Given this list of marker genes Upb1, Ada, Dnph1, Upp2, Gda, Urad, Hprt1, Dpys, Slc29a1, Nt5c, Entpd1, Nt5m, Upp1, Xdh, Dpyd (dihydropyrimidine dehydrogenase), Nt5c3, Nt5e, Gmpr2, Cda, Nt5c1a, Pnp, Nt5c2, Nt5c1b, Tymp, Urah, Ampd3 (NCBI Gene Id 11717), Uox, here is a description of the gene set: Mouse Gene Set: GOBP_NUCLEOSIDE_MONOPHOSPHATE_CATABOLIC_PROCESS studied in species Mus musculus The chemical reactions and pathways resulting in the breakdown of a nucleoside monophosphate, a compound consisting of a nucleobase linked to a deoxyribose or ribose sugar esterified with phosphate on the sugar.